Given this list of marker genes Eif3j1, Mrpl36, Sfr1, Gclm, Zfp108, Nrip3, Ncf1, Rora, Mapk8, Cpsf6, Kcnv1, Ptprr, Slco1a1, Gkap1, Lsm14a, Canx, Arf6, Grm1 (NCBI Gene Id 74875), Jag1, Ier2, Zfp451, Sirt2, Tnik, Dipk2a (divergent protein kinase domain 2A), Tdpoz9, Ptprg, Arfgef1, Nanos1, Ankfy1, Rbfox1, Eif3j2, Phaf1, Cpeb2, Fcrl1, Hecw1, Ccdc88a, Nr2c2, Klhl13, Creb1, here is a description of the gene set: species: Mus musculus from publication Chen Y, Wang X (PMID 31504780) Genes predicted to be targets of miRBase v22 microRNA mmu_miR_449c_3p in miRDB v6.0 with MirTarget v4 prediction scores > 80 (high confidence targets). Mouse Gene Set: MIR_449C_3P